Given this list of marker genes Baat, Ces1a, Ces1d, Pex2, Akr1d1, Ces1h, Hsd17b10, Cyp7a1, Slc27a5, Slc27a2, Errfi1, Hnf1a, Star, Malrd1, Fgfr4, Nr1d1, Amacr, Ces1g, Prox1, Ces1c, Stard4, Ces1f, Fgf15, Ces1e, Abcd3, Cyp27a1, Sirt1, Cyp8b1, Acox2, Cyp7b1, Cyp39a1, Ces1b, here is a description of the gene set: The chemical reactions and pathways resulting in the formation of bile acids, any of a group of steroid carboxylic acids occurring in bile. studied in species Mus musculus Mouse Gene Set: GOBP_BILE_ACID_BIOSYNTHETIC_PROCESS